The following is a description of a gene set: Genes negatively correlated with memory B cell response at 28d in peripheral blood mononuclear cell in seniors (50-74) after exposure to Fluarix, time point 3D studied in species Homo sapiens Human Gene Set: HARALAMBIEVA_PBMC_FLUARIX_AGE_50_74YO_CORR_WITH_28D_MEM_B_CELL_RESPONSE_AT_3DY_NEGATIVE from publication Haralambieva IH, Ovsyannikova IG, Kennedy RB, Zimmermann MT, Grill DE, Oberg AL, Poland GA (PMID 27317456) BACKGROUND: Studies suggest that the recall-based humoral immune responses to influenza A/H1N1 originates from activated memory B cells. The aim of this study was to identify baseline, early and late blood transcriptional signatures (in peripheral blood mononuclear cells/PBMCs) associated with memory B cell response following influenza vaccination. METHODS: We used pre- and post-vaccination mRNA-Seq transcriptional profiling on samples from 159 subjects (50-74years old) following receipt of seasonal trivalent influenza vaccine containing the A/California/7/2009/H1N1-like virus, and penalized regression modeling to identify associations with influenza A/H1N1-specific memory B cell ELISPOT response after vaccination. RESULTS: Genesets and genes (p-value range 7.92E(-08) to 0.00018, q-value range 0.00019-0.039) demonstrating significant associations (of gene expression levels) with memory B cell response suggest the importance of metabolic (cholesterol and lipid metabolism-related), cell migration/adhesion, MAP kinase, NF-kB cell signaling (chemokine/cytokine signaling) and transcriptional regulation gene signatures in the development of memory B cell response after influenza vaccination. CONCLUSION: Through an unbiased transcriptome-wide profiling approach, our study identified signatures of memory B cell response following influenza vaccination, highlighting the underappreciated role of metabolic changes (among the other immune function-related events) in the regulation of influenza vaccine-induced immune memory., and this is the list of marker genes: NDUFA6, SPSB2, INPP5B, PSMD13, ZFP14, SLC39A8, HNRNPU, PTGES3, HNF1A, SRI, ACTL10, SLC30A7, ZNF763, EEF2KMT, MLH1 (mutL homolog 1), DOCK7, TADA3, DDB1, C14orf132, NAP1L4, PREPL, ARL17A, SRSF1, PPIE, CEMP1, ST8SIA1, ZNF850, HTRA2, LINC01011, FUT2, UBE2Q2, API5, PGAP3, ZNF302, COX15, COA5, CCT4, PRR5, FOCAD, ERP29, HCFC2, HCST, FAT2, GATD3, NOM1 (NCBI Gene Id 93130), HDHD3, MAVS, GIN1, COPS4, RBIS, ATP5MK, CXCR6, PHTF2, ELAC1, TBCD, CYP20A1, KLRG1, KRT1, S1PR4, ATG10, HNRNPA3 (NCBI Gene Id 220988), FKBP4, LMAN2L, RDH16, C11orf68, TMEM50B, ZFP62, CMBL, KRIT1, IL16, DNAJC19, RECQL5, TBC1D24, MPPED2, TMEM79, ZNF75D, NSMCE1, AKTIP, SURF4, CDKL3, TDRKH, RNASEH2B, KLHDC3, OGFOD3, APEH, CLIC5, ITGB1BP1, RTCA (NCBI Gene Id 8634), BOLA3, ORMDL2, MICOS10, ANAPC7, IGFBP4, MRPL19 (mitochondrial ribosomal protein L19), TTC1, POLR3K, SMARCC2, MRPL30, C9orf43, EPCIP-AS1, UBAC2, LYSMD2, NFATC1, SV2A, ZNF527, CHMP6, EIPR1 (NCBI Gene Id 7260), RPL39L, C1orf216, APC2, MRPL48, BTBD10, EIF2S2, EIF2B4, SEMA4G, PRPSAP2, LYRM7, RNF220, CEP250, MAGOHB, PFDN5, ZNF737, KBTBD3, C18orf54, CWF19L2, ZFR2, SEM1, TAF1, POLH, TMX2, ZSWIM7, LAGE3, ZMYM5, KIFAP3, COQ4, MRPS9, SERGEF, HMOX2, TIGD7, CRTC1, RIC8B, TINF2, RNASEH2C, KMT5B, AP2B1, MACROH2A2, STAT5A, VBP1, FCRLB, SKA2, EIF2B3, RPS24, B3GNT2, ACTR6, MRPS5, PPP2R5C, PPIP5K1, UBL5, UBE2D2, ZNF28, ZNF780B, ANKRD13C-DT, NAALADL1 (N-acetylated alpha-linked acidic dipeptidase like 1), THOC7, CCDC81, MED4, C2orf74-AS1 (C2orf74 antisense RNA 1), PCYT2, APOBEC3D, ANGPT2, PDP2, MRPS25, DGUOK, NMRAL1, NFATC3, RBM14, MCTS1, ZNF404, NDUFS5, JPT2, CARD8, CDK4, NTHL1, C4orf3, GTPBP10, BUB3, SARS1, ALDH9A1, DNAJC8, GLE1, PSMD4, CNPY2, ARHGAP30, GLG1, SYTL2, FLAD1, MFF, ZNF506, MAP7D3 (MAP7 domain containing 3), BLCAP, MRPS12, UGGT1 (NCBI Gene Id 56886), CEP44, SCAND2P, DUSP19, NIF3L1, PDCD10, RPL32, NEDD8, DNAL4, RANGAP1, ST7L, FAHD2B, AGL, MROH7-TTC4, C17orf75, DCTN5, CEP89, PARG, MRC2, MDP1, ACBD4, SERF2, DMAC1, ARHGEF4 (Rho guanine nucleotide exchange factor 4), MOB2, SCOC, RTN4RL1, PAAF1 (NCBI Gene Id 80227), CBR4, TRIM65, LYSMD1, ZNHIT6, NPDC1, KCTD7, SAYSD1, IFT27, ZNF674, GNPNAT1, LRPPRC, USP5, ATP5F1D, RNF8, RPL23A, NDUFS2, OXSM, AKAP12, AGFG2, GOT2, MDM1, ZMAT2 (NCBI Gene Id 153527), HSPBP1, ZNF780A, MRPS16, PURA, SMIM20, TMEM107, ZNF320, FBLN5, SNU13, SF3A3, ZNF584 (zinc finger protein 584), EIF5B, PLEKHH1, TRIM2, MMAB, GOT1, COG6, RNF14, CERK, CHRNB1, MRPL51, METTL6, DUT, PHB1 (prohibitin 1), SNX5, SCAMP3, ZNF585A, SPRN, MTRES1, SLF2, ZNF738, NHLRC4, VAPB, MAF, DHDDS, PTPRN2 (protein tyrosine phosphatase receptor type N2), LCMT1, ABRACL (NCBI Gene Id 58527), YY1AP1, TAFA1 (TAFA chemokine like family member 1), SNRPC, TMEM186, THYN1, PMVK, MAEA, DCP2, GPATCH4, MRPS14, SARNP, UPF3B, NAPEPLD, C1orf56, AOPEP, PRKRIP1, COA8, GFOD2, KYAT1, CD2BP2, ATPAF1 (ATP synthase mitochondrial F1 complex assembly factor 1), DHRS13, ELAVL1, TTLL1, LSM2, C19orf25, MAP4, PIN4, INTS13, ZNF233, ZNF610, TMEM203, KIF3A, PRMT2, PDLIM2, PDZD11, KRT10-AS1, KLHL9, HMGCL, NFS1, ZC3H6, PIGP, SUGT1, TNNC1, AP2A2, COPZ1, RAD51C (RAD51 paralog C), FAIM, TMCO1, N6AMT1, RFPL2, SPAG16, SNORD34 (NCBI Gene Id 26817), TIPRL, ARFRP1, LITATS1, GNL1, TRPV2, CNPY4, ZNF197, AFAP1-AS1, ZFP2, CLHC1, UQCR10, MIEF2, WDR83OS, LYAR, SUCLG1, SYNRG, ALG6, DIAPH1, NOP14-AS1 (NOP14 antisense RNA 1), INSIG2, NME7, GPD1L, KDM5A, EARS2, NUDCD3, HENMT1, LRRC45, RBMX2 (NCBI Gene Id 51634), ZNF12, RNF32-DT, RANGRF, ST20, FDXR, PYGO2, DCTPP1, GTF3C1, NAA38, SPN, AMACR, MADD, ATAT1, MYL6, STRADA, PRR13, ZNF445, VEZT, NDUFB2, MRPS7, MYO18A, FDFT1, BMS1, FCF1, APOBEC3H, FBXO22, PHF20, HTT, ANXA2R-OT1, CSTF3, TMEM248, CYB5B (NCBI Gene Id 80777), MDH1, RAI14, SHF, POT1, ZNF232, RRP1, PABIR1, TRAPPC2, PSMG3-AS1, MBP, GOSR2, TMEM258, ZNF500, KRBOX5, MAPT, SIRT5, HIF1AN, HIRIP3, NFU1, VPS72, RABEPK, RINL, UNC13D, MAPDA, GIMAP1-GIMAP5, GOLGA7B, DTYMK, DCAF8, GIMAP1, PARP1, C22orf39, PSMC6, PKNOX1, ZNF626, MCRIP1, EYA3 (NCBI Gene Id 2140), ARMC7 (armadillo repeat containing 7), ARHGEF19, THAP3, ATP5MC2, TMEM67, PAQR8 (progestin and adipoQ receptor family member 8), COMMD6, RPA2, NCBP1, SIRT4, ASB1, PCNX3, HSPA1L, TFB1M, LRP11, HOXB2 (NCBI Gene Id 3212), MRPL57, TRAPPC6B, PSME3IP1, ACTR10, PPP1R12B, UBE2I, BUD13, GGPS1, RPA1, SNRPD3, ZNF260, TMEM216, KLHL22, EXOSC7, ZNF559, SETDB2, RFC4, CLYBL, JRK, USP37, MTHFSD, UBE2L3, RNF25, ZNF84, RALA, PCID2, PDCD11, CYB561D1 (cytochrome b561 family member D1), DNAJC24, PEF1, ERG28, FBXW2, RNF167, RPL15, SRPRB, ZNF480, TRAPPC4, FLVCR1-DT (NCBI Gene Id 647824), LYPLA2, ZNF701, SPRYD3, UNC45B, MTLN, APOBEC3F, PXMP4, CTU1, TRNAU1AP, CDRT4, SETD4, SPOP, CCDC34 (coiled-coil domain containing 34), LINC00324, HLTF, LMAN2, SAP30L, QDPR, CAAP1, BOD1, USP40, UQCRB, CERS5, TEX264, PDK2, WDR77, NDFIP2, MLH3, DBT, TAF15, TPRG1, FKBP3, ANGEL2, MRPS18B, MRPS33, ALDH5A1, SPEF2, PPA2, SEMA4F (NCBI Gene Id 9408), ZFTRAF1, ZNF568, PIGU, CACNA1C, CCDC61, IGSF8, PYM1, HDDC3, ZDHHC13, UQCR11, PAGR1, UBAC2-AS1, ING4, LEO1, CCDC167, MIPEP, BORCS5, CBX3, TGDS, FRA10AC1, METTL2A, NEIL2, RETREG3, ATRIP, PPP2R5D, PPP2R1A, CHMP4A, RPL39, ZNF621, STBD1, BDH2, JMJD4, XPO1, ATP5F1EP2, SMIM29, MKS1 (MKS transition zone complex subunit 1), ABCC5, FARSB, TOMM5, CCM2, METTL23, PWWP2A, AHSA1, LSM4, CLNS1A, UGP2, BCAP31, MESD, LRTOMT, UNG, CPNE7, OSGEP, SCAP, CISD1, ASB2, RTP5 (receptor transporter protein 5 (putative)), RAB22A, NBAS, ATP5IF1, TLN2, ASTN2, CDPF1, SDAD1, CDADC1, RER1, MRPL35, THOC3, ICE2, RBM4B, WDR35, SNUPN, SNORD50B, PHF19, PFKL, ZNF226, LSM5, TMEM120B, CIPC, TMA16, BPNT1, L3MBTL2, RFESD, CPNE1, ZNF696, C17orf100, RFT1, DLGAP4, LBHD1, TNFAIP8L1, NDUFA2, CABIN1, COPS5, MED22, MVK, VRK3, ZNF619, SNORD36C, ZNF48, EEF1AKMT3, RIOX2, HIKESHI, TTC9, YAF2 (YY1 associated factor 2), TRIP4, AAGAB, SF3B3